Given this list of marker genes Msn, Vangl2, Ahi1, Cdc42, Crb3, Lama1, Sapcd2, Myo9a, Zdhhc7, Celsr1, Spag6l, Traf3ip1, Fzd6, Sec24b (NCBI Gene Id 99683), Rhoa, Sfrp5, Camsap3, Brsk1, Fat4, Wdpcp, Brsk2, Dchs1, Alms1, Actb, Scrib, Pafah1b1, Wdr1, Ttc8, Actg1, Nphp1, Rab10, Pkhd1, Intu, Sfrp1, Cthrc1, Sfrp2, Dlg5, Ift20, Grhl3, Jhy, Ptk7, Wnt9b, Astn2, Ajap1, Exoc5 (exocyst complex component 5), Fuz, Foxf2, Tcf15, Ctnnd1, Rpgrip1l, Fzd3, Lama5, Cplane1, Ophn1, Syne4, Fat1, Nherf1, Sh3bp1, Trp63, Foxf1, Dlg3 (NCBI Gene Id 53310), Erbb4, Wnt5a, here is a description of the gene set: species: Mus musculus The morphogenetic process in which the anatomical structures of a polarized epithelium are generated and organized. A polarized epithelium is an epithelium where the epithelial sheet is oriented with respect to the planar axis. Mouse Gene Set: GOBP_MORPHOGENESIS_OF_A_POLARIZED_EPITHELIUM